Given this list of marker genes FGL2, FAM89B, SPDL1, SH2D2A, ACTB, LAMTOR5, PRDX4, GZMA, ACYP2, RSU1, ATP5IF1, SIRT2, CDKN2C, TCF19 (NCBI Gene Id 95292), LAMC1, IL18RAP, HOPX (HOP homeobox), ETFB, BCL2A1, ANXA6 (annexin A6), NDUFB6, ID2, MED12L (NCBI Gene Id 57726), DAPK2, DKK2, MBD2, PTPN13, S100A6, SLC66A3, MDFIC, AIP, LIG1, TMEM160, CTLA4, SMAP1, ATP6V0E1, NRP1, PALD1, RFC4, TXNDC5, REPS1, ANXA2, P3H4 (prolyl 3-hydroxylase family member 4 (inactive)), LGALS3, WNT3, IL10RA, PSMB10, ACTN4, HMGB2, CD160 (CD160 molecule), CHD7, CAPN2, FADD, AURKB, PLSCR1, AHNAK, DLGAP5, PCYT1A, SNTB2, ARHGDIB, PRIM2, SGO1, DHRS1, TTK, HASPIN, KLRG1, MAPRE2, BTF3, IL18R1, STAB1, COMMD1, LSM1, TMEM37, CXCR3, ENSG00000286190, CDC34, CDKN3, PRELID1 (NCBI Gene Id 27166), SNX10, CASP4, BIRC5, BATF, PGLYRP1, HSD11B1, GZMK, PRF1, DBI, GLRX, BSCL2, HK2, GSTT1, CASP7 (caspase 7), FRG1, S100A11, RAC2, NDUFB7, GNPDA1, NDUFV3, REEP5, TSPAN31, FASLG, LGALS1, IFITM10, ITGAM, ACTC1, MT2A, CTSA, KLRK1, YBX3, RNF14, PTGR1, ITGAX, RORA, CCR5 (C-C motif chemokine receptor 5), GABARAPL1, RPS6KA4, ELOVL1, GALNT3, ITGB1, RNF19B, CARHSP1, KCNJ8, STARD10, LPIN1, CRIP2, GZMB, PADI2, CTSD, ADAM19, KIF22, CCR2, PSMD8, CCL5, RACGAP1, GABARAPL2, PPIB, CCNE1, GNG11, SNRNP27, DCPS, TSPO, ACOT7, MRPL27, LRP10, RHPN2, ITGAL, DENND5A, TRAPPC1, E2F8, MYO1F, COX17, CD68, DAP, ANXA1, MNS1, HLA-A, KLRC1, GEM, MIS18BP1, HOXD13, UNC119, PSMA2, CX3CR1, S100A10, ENTPD1, LXN, PRRC1, ITGA4, S100A13, DTL, DOCK5, XDH, ASL, JAK1, S100A4, MSRB1 (NCBI Gene Id 51734), CAPNS1, NDUFA8 (NCBI Gene Id 4702), ERRFI1, SH2D1A, PRR13, ST3GAL4, BHLHE40, PTTG1, SMYD1, CSTB, MRPS16, LITAF, CDK1 (NCBI Gene Id 983), ARF6, LMAN2, IFNG, FCGRT, MAPK3 (NCBI Gene Id 5595), AGPAT3, CD48, CASP1, FCGR2B, YKT6, here is a description of the gene set: CD8 T cells normally differentiate from resting naïve T cells into function effector and then memory CD8 T cells following acute infections. During chronic viral infections, however, virus-specific CD8 T cells often become exhausted. We used microarrays to examine the gene expression differences between naive, effector, memory and exhausted virus-specific CD8 T cells following lymphocytic choriomeningitis virus infection. from publication Wherry EJ, Ha SJ, Kaech SM, Haining WN, Sarkar S, Kalia V, Subramaniam S, Blattman JN, Barber DL, Ahmed R (PMID 17950003) Human Gene Set: GSE9650_NAIVE_VS_EFF_CD8_TCELL_DN studied in species Homo sapiens Genes down-regulated in comparison of naive CD8 T cells versus effector CD8 T cells.